Given this list of marker genes PRPS2, SPMIP10, C1QBP, MAN2A1, PLA2G2E, DTYMK, KHDRBS1, PIAS2, DPH5, SLAMF1, EIF3L, ERCC6L, FER, RPL31, NEFH, PINX1, NAF1, SELP, BRCA2, PTGER4, CASP4, WDR43, SRSF10, ANAPC13, MORC3, UBE2K, EFCAB14, PCBD2, CLUH, MLH1 (NCBI Gene Id 4292), HMGB1 (NCBI Gene Id 3146), USP10, PDE12, ABHD8, KRAS, IL18BP, TRIP13, FGF21, TEKT1, TRIAP1, EIF4ENIF1, GTPBP1, HTATSF1, NOLC1 (NCBI Gene Id 9221), PIGP (phosphatidylinositol glycan anchor biosynthesis class P), HYPK, RPAP3, FBXO45, RAI2, MRPL33, TPR, POGLUT1 (NCBI Gene Id 56983), ABHD10, BEX3, NT5C3B, NFKBIZ, DRAP1, GCLC (glutamate-cysteine ligase catalytic subunit), HSPBP1, MKLN1, PCLAF, WDSUB1, SAP30L, NOP56, PARP2, TRIM34, SSNA1, NUP85, SPC25, RSL24D1, MOGS, NHP2, PSIP1, RBCK1, PSMA7, KAT2A, ATM, PTPN9, RPL7L1, PTGES3, TSR2, TFDP1, CREBZF (CREB/ATF bZIP transcription factor), PUS7, WRAP53, FHL2, PRMT3, C2orf76, RIF1, ATP5MC3, CLNS1A, GYPC, DNAJA1, CDCA7L, MLC1 (NCBI Gene Id 654039), GCLM, TMPRSS5, EFR3A, MYO5A, TMEM14C, COQ6, RNPS1, MCM7, C9orf40, PDCD10 (NCBI Gene Id 9226), RIOX1, PABPC4, EWSR1, RTP4, PEX11B, PNP, PHIP, RDX, DYNLL2, ATP10A, SARNP, EXO1, DEK, NUTF2, UBE2J1, FANCI, NFATC2IP (nuclear factor of activated T cells 2 interacting protein), MRRF, RAN, IFI27L2, AP4S1, GNL3, C8orf76, BTF3L4, SMARCA5, DIAPH2, NRP1, ORC2, MAGOH, WDR75, PSMC4, CAND1, PPP2R5D (protein phosphatase 2 regulatory subunit B'delta), SCAF11, KRT17, LRRC20, FIG4, SFT2D1, SF1, PTPN11, DNAJC2, ACY3, ANKMY2, HEATR1, PITPNA, CDK1, ADA, NUP93, RRN3, PPP2CA, NUP37, SP2, E2F6, DDX39A, SNRPA1, SSBP1, FTSJ3, AKR1B1, HTT, E2F8, DNAJC27, MTFR2, DIS3, ZCCHC3, UBE2G1, PDS5A, LRRC8C, MED28, SNRPG, SAP18, DLST, MIS18A, ALYREF, SGF29, PNO1, CPSF7, HNRNPDL, GTF3C4, KTI12, MCM5, DPP3, PRPS1, PRDX1 (peroxiredoxin 1), SF3A2, PTPN20, MTRR (NCBI Gene Id 4552), SLBP, POLL, U2SURP, AHCTF1, PTEN, LPGAT1, NDUFS8, CPOX, HARS1, here is a description of the gene set: from publication Rivollier A, He J, Kole A, Valatas V, Kelsall BL (PMID 22231304) Dendritic cells (DCs) and macrophages (MPs) are important for immunological homeostasis in the colon. We found that F4/80hi CX3CR1hi (CD11b+CD103-) cells account for 80% of mouse colonic lamina propria (cLP) MHC-IIhi cells. Both CD11c+ and CD11c- cells within this population were identified as MPs based on multiple criteria, including a MP transcriptome revealed by microarray analysis. These MPs constitutively released high levels of IL-10 at least partially in response to the microbiota via an MyD88-independent mechanism. In contrast, cells expressing low to intermediate levels of F4/80 and CX3CR1 were identified as DCs, based on phenotypic and functional analysis and comprise three separate CD11chi cell populations: CD103+CX3CR1-CD11b- DCs, CD103+CX3CR1-CD11b+ DCs and CD103-CX3CR1intCD11b+ DCs. In non-inflammatory conditions, Ly6Chi monocytes differentiated primarily into CD11c+, but not CD11c- MPs. In contrast, during colitis, Ly6Chi monocytes massively invaded the colon and differentiated into pro-inflammatory CD103-CX3CR1intCD11b+ DCs, which produced high levels of IL-12, IL-23, iNOS and TNF. These findings demonstrate the dual capacity of Ly6Chi blood monocytes to differentiate into either regulatory MPs or inflammatory DCs in the colon, and that the balance of these immunologically antagonistic cell types is dictated by microenvironmental conditions. species: Homo sapiens Genes up-regulated in dendritic cells versus macrophages sorted as ITGAX int and EMR1 high. Human Gene Set: GSE27859_DC_VS_CD11C_INT_F480_HI_MACROPHAGE_UP